The following is a description of a gene set: Human Gene Set: GOBP_NEPHRON_TUBULE_FORMATION The developmental process pertaining to the initial formation of a nephron tubule from unspecified parts. A nephron tubule is an epithelial tube that is part of the nephron, the functional part of the kidney. studied in species Homo sapiens, and this is the list of marker genes: PAX8, IRX3, GREM1, CTNNB1, HES5, PAX2, SIX1, SOX8, WNT6, SOX9, IRX2, HS2ST1, IRX1 (NCBI Gene Id 79192), GDNF, HNF1B, SIX4, OSR1, GATA3, NOG, WNT9B